Given this list of marker genes STAT5A, ZFP36 (NCBI Gene Id 7538), PDE2A, FCAR, PDE1B, AKT1, ETV3, CSF2 (colony stimulating factor 2), PRLR, ZFP36L2 (ZFP36 ring finger protein like 2), CD4, NPR2, here is a description of the gene set: species: Homo sapiens Human Gene Set: GOBP_RESPONSE_TO_GRANULOCYTE_MACROPHAGE_COLONY_STIMULATING_FACTOR Any process that results in a change in state or activity of a cell or an organism (in terms of movement, secretion, enzyme production, gene expression, etc.) as a result of a granulocyte macrophage colony-stimulating factor stimulus.